The following is a description of a gene set: NCAM signaling for neurite out-growth Mouse Gene Set: REACTOME_NCAM_SIGNALING_FOR_NEURITE_OUT_GROWTH species: Mus musculus, and this is the list of marker genes: Col3a1, Col4a1, Mapk1, St8sia2, Col4a4, Col6a3, Rps6ka5, Fyn, Col6a6, Sptb, Col5a2, Sptbn5, Col6a1, Grb2, Spta1, Col4a3, Col9a1, Col2a1, Sptbn1, Sptbn2, Col4a2, Sos1, Sptbn4, Col6a5 (collagen, type VI, alpha 5), Sptan1, Col5a1, Mapk3, Col9a2, Ptk2, Col5a3, Col4a5, Col9a3, Creb1, Hras, Kras, St8sia4, Col6a2, Ptpra